Given this list of marker genes EIF2B2 (eukaryotic translation initiation factor 2B subunit beta), WDR48, AAAS, CCDC171, RHOV, RANBP1 (RAN binding protein 1), EDEM2, TTPAL, TRAPPC12, DYNC2I2, SAMSN1, ATP2C1, CADM1, ING4, APOLD1, C1orf122, MRPS18B, CDC45, RAB5C, COX15, WDR74, CCDC85B, NIPBL (NIPBL cohesin loading factor), ACP2, FCHO1, ACSL4, PIGC, CIAO2B, ELP2, C2orf49, FBXL9P, CD2BP2, MRPL3, ANKS1A, FCN1, BDNF, KDF1, FIBP, CHERP, PHF12, SPTY2D1, JUNB, BTAF1, CSTF1, PILRA, CRADD, YTHDF3, PRKAG2, SOWAHC, MAP4K2, HSP90AB1, TNKS, NMNAT1, RAP2C, TFE3, HOXA11, LRRC59, FGD2, ZNF512, DAPP1, DUSP5, UGGT2, TFRC, TMBIM4, COMMD5, ITGB7, GAB2, SYNCRIP, PTBP3, ZNF830, AGPAT4, YWHAB, NPTX2, CIB1, PRDX5, TRMT2A, PLCB3, AOPEP, IRF2BPL, BIN3, SYNJ1, CCAR2, LIN28A, ELF4, TCF7, ST7L, AAK1, PPP1R21, ALDH16A1, ARHGAP45, SOX2, CTSS, HBEGF, HERC4, TIMP4, STK4 (serine/threonine kinase 4), SMU1, FIS1, APPL2, TAF11, TACO1, ZCCHC9, NHERF1, PYROXD1, TMEM33, BAG4, UXT, NIPAL3, TNNI2, LTBR, LPXN, GNAI3, FBXO28, DGUOK, ATP6V1A, SNHG29, IGF1R, TAOK2, BRD9 (bromodomain containing 9), PTPN2 (protein tyrosine phosphatase non-receptor type 2), IKBKB, RPS6, GPALPP1, PKN1, IL18BP, TXN2, PRIM2, WDR83, MLEC, TNFRSF13B, GLA, EXOC5, NIF3L1, GFI1, DMBT1, TCF12, VEGFB, ARPC4, GALNT10, CITED2, ACTR6, LCOR, EML3, GRWD1, ACSL5, WDFY4, CBFB, STARD13, NAA60, NMRK1, RAB7A, DMP1, SOCS4, BIN2, CKS1B, MAD2L1BP, CPEB4, OMA1, EXTL2, KICS2, PIK3R2, CDC5L, TMEM62, CDX2, SUPT16H, MAGED1, NAA50, GPC4, YRDC, RNPS1, CARD9, MITF, DDIT3, SHC3, PRKACB, CACNA1D, DNAI1, LINC03124, RING1, ELMO1, PICALM, LIMD1, EIF2S1, LZIC, PDZD7, MTMR14, PFKFB1, PDIA3, BRF2, CYTOR, ZRANB2, VASP, PRKACA, ZNF24, RLIM, SPRR4, MARK1, RAB4B, MARK3, LIMK2 (NCBI Gene Id 3985), BCLAF1, ZBTB7A, SLF2, CYB5R4, C2CD2L, MTPN, PIK3CG, DPCD, FGD1, CLDN12, LRRC41, C3orf38, TCOF1, TRMT2B, EMG1, SLC39A9, SEC24C, ARRB2, CRB3, ULK4, AGL, ERCC1, HOXA1, ZMAT3, EAPP, KBTBD4, PATZ1, PAFAH1B2, TUSC3, TRIP13, RBMS2, NFATC3 (nuclear factor of activated T cells 3), RNF20, ACTB, BAX, PTGR3, MORF4L2, BMF (NCBI Gene Id 90427), DNAJB9, TBP, RUNDC3A, FUCA1, ZCCHC24, EYA1, IL13, ZSCAN20, UBE4A, DIAPH1, PRF1, CIAO1, FBXW9, ELOVL1, FAM210A, SLC38A10, THAP11, NUP155, PYM1, SLC41A1, RPL27, WIPI1, GSPT2, DDX39B (DExD-box helicase 39B), ATP10B, FLT1, CHPF, BCL2L1, MORC3, PML, CTDSP1, PHF23, CHUK, RPS18, HAUS3, PCED1A, FOXP1, CTPS2, CCZ1B, CREB3, POGZ, TRIM41, APEH, ZMYND8, ZFP3, PATJ, ZNF22-AS1, MIDEAS, ISCU, PSENEN, SRSF9, HSPH1, TAF5L, DPP8 (NCBI Gene Id 54878), CSAD, ARHGEF6, PIH1D1, CLINT1 (NCBI Gene Id 9685), GSKIP, ZKSCAN8, IL2RA, C9orf40, MINDY1, CD40LG, UFD1, GRIN2B, OPA3, SCAMP2, RAE1, TLK1, PCGF1, SNCAIP, PTPN12, SCRT2, ZNF653, CDK11B, TMEM9B, DNAJC7, TMCO1, AP4E1, SUMO1, METTL25B, TIMM10B, ROM1, CDH2, SLC35B3, ELK4, ATP6V0E1, NOC2L, PPAN, NUDT21, C16orf46, ENDOV, CCT7, RMC1, SLC39A6, ZNF655, LEPROTL1, ZNF408 (NCBI Gene Id 79797), ZBTB10, JPH4, VAV1, CCDC25 (coiled-coil domain containing 25), LSR, ESM1 (endothelial cell specific molecule 1), MSANTD2, CARF, C11orf24, C14orf119, POLR2H, ATP7A, XPO5, CAAP1, VPS52, U2AF2, MKRN3, CTTNBP2NL, ZNF23 (zinc finger protein 23), FXYD5, AGAP2, CUTC, HNRNPH2, TAF5, DIABLO, ZNF184, PPIL3, PPP1R10, DPYSL3, SEC31A, KLHL17, RAB2B, USE1, PREX1, RARB, RNMT, MLF2, MGAT4A, UBR4, PSMD13 (proteasome 26S subunit, non-ATPase 13), TNRC6A, SIPA1, E2F5, ARPP19, DGKA, HNRNPA0, LAYN, CDK8, DES, DNMT1, TMEM128, MPZL3, TTF1, FAM110A (family with sequence similarity 110 member A), SLC39A11, BAG6, LIMD2, ARHGAP4, TIMM17A, EIF4A1, ARAP1, CD53, PICK1, UBE2F, NASP (nuclear autoantigenic sperm protein), MED26, SRSF4, CES2, ZNF585A, GIT2, GGA1, PDLIM2, GGT7, INO80E, DCTN5, FURIN, FFAR4 (free fatty acid receptor 4), SEPTIN10, HAT1, SIK3, PRADC1, PER2, ADNP2, SF3B4, TJP2, ERH, GEN1, RGS3, SLC30A7, APOBR, ARHGAP1, RNF44, PSMB7, SIT1, FBXO8, COPS3, GNL3L, SLC12A4, NIPAL2, PHB2, XRCC4, SART3, VMP1, ARFIP2, PPP1R11, PPP3CA, MTFR1L, LAMC1 (NCBI Gene Id 3915), CYB5R3, ARPC1B, GTF2H1, DPP3, POLL, WDR83OS, HSPA8, CUL7, NME2, PKIB, AP1M1, ATL3, SLAMF9, SOX10, ZFP64, RPA2, ZNF384, ZFAND3, MMRN2, CNTN4, MAGED2, KLHDC4, SNX16, MAPRE1, GFOD1, UBE2N, CAP1, RGS14, POLR3D, PTRH2, TOR4A, CHM, RPS11, ETF1, AP3S2, NDRG1, HYAL2, IL12B, SMARCA1, CATSPER2 (cation channel sperm associated 2), RINL, LSM5, SMC6, CBX8, IL11RA, MTF1, ZC3H10, TUT1, ZDHHC5, SLC39A13, INTS3, TMEM127, TADA3, PALB2, TNPO3, CNOT10 (CCR4-NOT transcription complex subunit 10), PLCB2, SSH2, GPR137B, CELF1, INVS, PTPN1, SPINDOC, SEMA4C, CAPZA1, TMX1, MPDU1, TRMT112, LAPTM5, E2F3 (E2F transcription factor 3), LMAN2, STK10, RIPOR1 (NCBI Gene Id 79567), AURKA, VCAM1, ZBTB11, KYAT1, MTMR4 (NCBI Gene Id 9110), ATP6V1D, HIRIP3, DDX47, WDR73, LCP1, NRAS, ZNF79, RTEL1, BCAT2, TAF8, DMTF1, UNC13D, RFC4, DOCK8, SEC23IP, UBE2L3, ZNF322 (NCBI Gene Id 79692), TAF2, ITPR3, SHC1, CCR7, FRS2, POLH, TRPV2, CPNE8, TXNDC12, UQCRH, ZFYVE16, CAST, SERINC1, RGL2, WDR1, CANX, VPS16, PRTN3, ENTR1, YKT6, ETV5, LCMT2, DCAF10, TNS2, ZNF646, AMD1, EXOC7, PPP1R14C, CD247, TPI1P2, TM9SF1, CD79B, RALB, NR4A2, SNCG, PRKCSH, CXCR3, RNF4 (NCBI Gene Id 6047), TBC1D10C, ELOVL6, R3HDM1, UFC1, EIPR1, LYRM1, POMP (proteasome maturation protein), SVIL, CLCN2, ATG5, TMEM154, SPRY2, NDUFS3, NRBF2, ODAD3 (outer dynein arm docking complex subunit 3), COX17, TMUB1, TGIF2 (NCBI Gene Id 60436), RPL41, RPL37, PEX2, DDOST, ARHGAP15, MTCP1 (NCBI Gene Id 4515), BATF2, KAZALD1, PSMB1, PILRB, ATOSB, ETV3, FBXO22, FNTA, ELOVL5, MON1B, BMP4, BRCC3, RBM22, CORO1C, XCL2, ZNF22, CCR6 (NCBI Gene Id 1235), ERF, GNL2, LANCL3, SYNRG, EDC4, MFNG, HM13, CNOT1, UVRAG, EGR2, BNIP2, TLN1, PAIP2, TMEM167A, ZNF668, TRIM39, FAM13B, TMEM208, DDX50, ITFG1, ISG20L2, LCP2, SOST, VPS13B, ITGA11, LIME1, TRO, XCL1, ZNF35, SIRT3, LSM1, RPS6KA3, CDK13, SGO2, ZNF800, PAX6, DGKZ, ARL5B, FAM219A, ITPRIPL1, RPSA, EIF5A, WIPI2, GMPR2, CWC25, GAR1, HMGA1, TWIST1, PEX7, WIPF1, ADNP, GTF2A2, TMEM156, CYTH4, SF3A1, RAB1B, UBE2V2, CEP135, NME1, NSD1, UBE2D3, TBCC, WDHD1, MBNL1, USF1, DCUN1D3, VAMP8, RIN1, UBXN1, ARHGEF7, TOMM40, CMAS, KIF5B, CDK5, ELK3, HPS5, AP5M1, MAP9, WDR55, SLC26A9, FEZ2, PHKB, TLR4, ACIN1, NF1, ZER1, NEDD8 (NCBI Gene Id 82917), KIF3B, ZNF768, ING2 (NCBI Gene Id 3622), TEAD3, FIGN, GPR84, DEPDC4, ASPHD1, PCDH7, BMP2K, NOL12, KAT5, PAFAH2, SZT2, CDK11A, CMTM6, SEC11A, NCAM1, CLMN, NDN, SEPTIN1, PRKAG1, NUFIP1, MFN2, CPT2, BCAS3, EDC3, THAP5, CFAP68, CEP164, EVI2B, ITPR2, LTO1, CEP44, CSGALNACT2, OSTF1, TAX1BP1, ZBTB41, YJU2, FGF20, PHLDB3, SEC13, NKIRAS2, SSBP3, HERPUD2, MYG1, VPS53, TNFSF11, FMR1, CSRNP3, HOXC4, CFAP36, GTSF1, RIPK4, PPME1, PIK3R4, U2AF1L4, PACC1, CCT6B, ZNF585B, CHMP1B, CTR9, TUFM, DHX8, SUGP1, here is a description of the gene set: Genes having at least one occurrence of the highly conserved motif M11 MGGAAGTG in the regions spanning 4 kb centered on their transcription starting sites. This matches the GABPA, GABPB2 transcription factor binding site V$GABP_B (v7.4 TRANSFAC). from publication Xie X, Lu J, Kulbokas EJ, Golub TR, Mootha V, Lindblad-Toh K, Lander ES, Kellis M (PMID 15735639) Human Gene Set: MGGAAGTG_GABP_B studied in species Homo sapiens Comprehensive identification of all functional elements encoded in the human genome is a fundamental need in biomedical research. Here, we present a comparative analysis of the human, mouse, rat and dog genomes to create a systematic catalogue of common regulatory motifs in promoters and 3' untranslated regions (3' UTRs). The promoter analysis yields 174 candidate motifs, including most previously known transcription-factor binding sites and 105 new motifs. The 3'-UTR analysis yields 106 motifs likely to be involved in post-transcriptional regulation. Nearly one-half are associated with microRNAs (miRNAs), leading to the discovery of many new miRNA genes and their likely target genes. Our results suggest that previous estimates of the number of human miRNA genes were low, and that miRNAs regulate at least 20% of human genes. The overall results provide a systematic view of gene regulation in the human, which will be refined as additional mammalian genomes become available.